The following is a description of a gene set: studied in species Homo sapiens In this study, we provide a molecular signature of highly enriched CD34+ cells from bone marrow of untreated patients with chronic myelogenous leukemia (CML) in chronic phase in comparison with normal CD34+ cells using microarrays covering genes. Expression data reflected several BCR-ABL-induced effects in primary CML progenitors, such as transcriptional activation of the classical mitogen-activated protein kinase pathway and the phosphoinositide-3 kinase/AKT pathway as well as downregulation of the proapoptotic gene IRF8. Moreover, novel transcriptional changes in comparison with normal CD34+ cells were identified. These include upregulation of genes involved in the transforming growth factorbeta pathway, fetal hemoglobin genes, leptin receptor, sorcin, tissue inhibitor of metalloproteinase 1, the neuroepithelial cell transforming gene 1 and downregulation of selenoprotein P. Additionally, genes associated with early hematopoietic stem cells (HSC) and leukemogenesis such as HoxA9 and MEIS1 were transcriptionally activated. Differential expression of differentiation-associated genes suggested an altered composition of the CD34+ cell population in CML. This was confirmed by subset analyses of chronic phase CML CD34+ cells showing an increase of the proportion of megakaryocyte-erythroid progenitors, whereas the proportion of HSC and granulocyte-macrophage progenitors was decreased in CML. In conclusion, our results give novel insights into the biology of CML and could provide the basis for identification of new therapeutic targets. Human Gene Set: DIAZ_CHRONIC_MYELOGENOUS_LEUKEMIA_UP Genes up-regulated in CD34+ cells isolated from bone marrow of CML (chronic myelogenous leukemia) patients, compared to those from normal donors. from publication Diaz-Blanco E, Bruns I, Neumann F, Fischer JC, Graef T, Rosskopf M, Brors B, Pechtel S, Bork S, Koch A, Baer A, Rohr UP, Kobbe G, von Haeseler A, Gattermann N, Haas R, Kronenwett R (PMID 17252012), and this is the list of marker genes: EIF1B, PTBP3, KCNK5, PKIG, UPF3B, RRN3, SELENOW, GTF2B, ACOT9, GUCY1B1 (guanylate cyclase 1 soluble subunit beta 1), HMGCR, ABL1, USP9X, PTPN12, DGCR2, NLK (nemo like kinase), H2AZ2, PDHX, MLLT10, RSL24D1, WDR1 (WD repeat domain 1), GEMIN4, SPTLC1, MBNL2, EIF2AK1, YTHDC1, ETFA, MYL4, TFDP1, GART, XRCC5, ZNF410, ITGA4, VPS33B, PPP2R1A, RPS27L, MAP4K4, DNMT3B, CNOT8, KLF1, TRAPPC3, SLC37A4, MCM3, DDB1, TIMM17A, EPOR, PPIH, AASDHPPT, IL1B, ENOPH1, ARRB1, CYP51A1, BTK, HSD17B12, MGAT4B, NBAS, MLH1, SNX3, ATXN10, NDUFB6, TCEA1, DPAGT1, MORF4L2, MEN1, KHDRBS1, CASP6, EIF1AX, CSNK2A1, FNTA, SLCO4A1, IL1RAP, PSMB2, SUB1, SLC2A1, CDK2, PSMD7, PSMA1, RHOH, PLXNC1, GTPBP4, VTI1B, PMP22, DHCR24, FLOT2, ARF3, EIF4E, SHMT1, TRIM13, ZEB2, TCEAL9, GNB2, TGFB1, ELOC, LMNA, SLC1A5, TTC33 (NCBI Gene Id 23548), FDPS, UQCRC1, PFN1, PNN, GDI2, ACTR1A (actin related protein 1A), SEC31A, NPAT, TFRC, RAP2B, PICALM, ALAS1, NDFIP1, PCK2, SOS2, GTF3C3, KCTD3, TIA1, MAP4K5, PMS1, TDG, HDAC1, CORO1C, GDE1, PIP5K1B, RBM7, EIF3A, ISCA1, GCDH, SLA, GTF2I, PSMD8, SNRPN, ZFAND6, AGPS, PRKAR2B, TFR2, FDFT1, BNIP2, YTHDF2, UBE2G1, S100A10, LCP2, FSCN1, SSBP1, GSS, UROD, UBE4A, SF3A3, MRPL3 (NCBI Gene Id 11222), PTBP1, VPS72, PTPN13, SH3BGRL, ENTR1, ACAT1, ARFGAP2, PFKP, ELP1, SNRPB2, RANGAP1, CALM1, AKAP1, CLC, UPF1, SLC25A15, SRSF9, EBAG9, MTCH2, TNFAIP1 (NCBI Gene Id 7126), TAF6, ATP7A, SLC2A10, PAPSS1, EIF5, FKBP5, SRP72, TAF7, PSMD10, TCF12, ZNF146, CAST, PSMA3, RAD50, OAZ2, PRMT5, POLR2B, ARPP19, GDF11, ACY1, SLC16A1, LBR, PARP1, ATP1A1, BLVRB, CCT8, POLD2, RRAGA, CBX1, CLNS1A, RPL31, USP14, WDR44, SNX4, RPN2, SIAH2, PACSIN2, CASP8AP2, SDF4, RP2, TBXAS1, UBXN8, LAT, PUM2, PRKAG1, GLT8D1, DAZAP1, TXNL1, CNPY2, NOLC1, KLHL12, MAP3K5, DRG1, HBD, SLC29A1, TBPL1, ACBD3 (acyl-CoA binding domain containing 3), CETN2, ECD, STAM, DLEU1, PABPN1, ITPRID2, MXI1, SPTBN2, SRSF1, PDCD6, DSTN, LYPLA1, COPS5, POLR2E, CALU, PPP4R1, DDX1, MED13, MAGOH, NGRN, DEAF1, CNBP, RNF5, MARCHF6, SQSTM1 (sequestosome 1), CUL4A, ATP5PO, TMX1, ENPP2, PPP3CA, FKBP4, SPTA1, SAMSN1, AGPAT1, PPP2CA, NPRL3, TOMM22, ELF4, PPM1D, PTPN7, P2RX5, SNRPG, TAF2 (TATA-box binding protein associated factor 2), ZMPSTE24, RAC1, BRCA1, PPP2R5E, RPA1, TMBIM1, NDUFAB1, DNM1L, KEAP1, SOD2, YEATS4, MPST, CBX3, CLEC2B, AMMECR1, CYC1, SMAD4, ATP5MC3, ARID4B, PSMD1, STAU1, HEBP2, HBS1L (HBS1 like translational GTPase), RBM5, CAPN7, QPCT, UCHL5, XPC, GLUD1, PFDN4, KARS1, HMGB1 (high mobility group box 1), TUBGCP4, HSPA13, NUDT4, RAB38, PPIE (peptidylprolyl isomerase E), HIBCH, POLR2C, MIPEP, PRPSAP2, MATR3, SEPTIN2, CHERP, KLHDC2, ACYP1, SERPINE2, HNRNPC, RBBP8 (NCBI Gene Id 5932), YY1, ACP1, ZNF22, FAS, MSH2, ARL1, MBD4, GCLC, SAV1, SMARCC1, DECR1, LPCAT3, MAPRE2, ATP6V1B2, ALDH6A1, CLPTM1, IMMT, SULT1A2, SNU13, HNRNPH2 (NCBI Gene Id 3188), TSC22D1, DEGS1, SPAG7, SF3A1, TMEM59, ATP6V1A, ACTR3, SLC5A3, TTF2, DGUOK, YES1, HSPH1, ACTL6A, BRD7, ZNF277, CAD, PEX2, FASN, CCDC6, ZFP36L1, MINPP1, LRRFIP2, PLAA, TOPBP1, SMC2, DCTD, PHYH, HBG1, XK, KDM3B, HEBP1, NDUFV2, HBB, MIF, INPP1, GMDS, NPEPPS, MAD2L1, EIF3C, LEPROT, INTS6, CDC7, PSMA7, SRPK2, CETN3, CCNH, APEH, ATP5F1B (ATP synthase F1 subunit beta), PRKD3, DYNC1LI1, BTBD1, DHX9, CITED2, TGM2, PDGFC, TM2D1 (TM2 domain containing 1), RAB31, MSN, GMCL1, IQGAP2, P4HA1, RTCB, NCK1, FXN, PITPNA, PRPF19, RTN4 (NCBI Gene Id 57142), RASSF1, SEC24B, USP11, CLPX, LUC7L3, EIF3B (eukaryotic translation initiation factor 3 subunit B), GMNN, TCP1, DDX11 (DEAD/H-box helicase 11), LSM8 (LSM8 homolog, U6 small nuclear RNA associated), SCAF11, NIF3L1, RBM3, AGL (amylo-alpha-1, 6-glucosidase, 4-alpha-glucanotransferase), TAF6L, CAPNS1, DLD, ITGA2B, POLR1C, MAP2K1, EIF3I, GBE1 (NCBI Gene Id 2632), WBP11, CDC16, COX15, CSDE1, POLE2, U2AF2, PGD, RNF6, PTPRA, HMBS, ADCY7, ABCE1, NET1, CENPS, IVD, NMT1 (N-myristoyltransferase 1), TIMM23, MAN2A1, PSMD12, MAEA, ATRX, PSMG1, TAGLN2, ADGRG1, PTGS1, TERF1, BIRC2, POLRMT, ITPR2 (NCBI Gene Id 3709), VDAC3, SOCS2, TRIP12, OXSR1, PRKACB, GMPR, METAP2, RBM39, WSB2, FRG1, BRD1, XPO1, SSR1, FEM1B, ACOT2, NFYB, DCTN4, FAM117A, COPS2, SMC4, F11R, G3BP2, DNAJC7 (NCBI Gene Id 7266), SRP19, UBE2K, POLE3, ELOVL5 (NCBI Gene Id 60481), RNF130, GATA1, DDX21, KIF22, CDC123, CYTH2, EIF4ENIF1, BAZ1A, LAMTOR3, HK2, CHD1L, LYN, EID1, MFNG, MPV17, ATP5MF (ATP synthase membrane subunit f), PRKAB1, DDX23, DNAJC12, CD59, ASMTL, ZNF134, FOXK2, SNW1, PPP2R5A, PRMT1, SRRM1, AKAP17A, COPA, ETFDH, NUP107, MAP7 (NCBI Gene Id 9053), AHR, PSIP1, HMGB3, HDC, PRDX4, ACVR1, ZNF207, LDHB (NCBI Gene Id 3945), TOMM20, SLC25A11, EIF2D, CAPRIN1, MLST8, GARS1, RSU1, CMPK1, NFATC3, RPS6KA3, ACTR2, SIGMAR1, AKT1, B3GALNT1, SMARCC2, ASL, SF3B3, CDC23, RFC4 (replication factor C subunit 4), CERS2, COIL (NCBI Gene Id 96825), CCT3, BCAP29, GTF2H4, STK11, UBE4B, HBQ1, CRBN, GOSR2, CD36, TOP1, NOMO1, KHSRP, RIPOR2, PPP2R5C, LY6E, ADH5, ITM2A, CISH, ERCC8, UBE2D3, RALB, GHITM, HOXA9, NUP50 (nucleoporin 50), PSMC3, PSMA2, NELFA, SRP54, OGDH (oxoglutarate dehydrogenase), HDAC3, RTN3, MAP2K2, FH, MRM2, STK24, RANBP2, CDK8, ATG12, SRSF10, C1QBP, NUDT6, CGGBP1, DNAJB6, WRN, RAP1GDS1, DCTN6, TSG101, TRA2A, HDGFL3, HIRA, DAG1 (dystroglycan 1), ADAM8, KPNB1, TUBGCP3, ATP5IF1, COPB2, BECN1, AMPD3, CD47, ADSS2, ORC5, ABCC1, PSMC1, RFC3, ENOSF1, MPP1, PNMA1, API5, NQO2, NCOA1, PSMB5, ANXA7, PTOV1, GLE1 (NCBI Gene Id 8012), RSC1A1 (NCBI Gene Id 6248), SREBF2, EHD1, PLP2, HDAC6, AUP1, PPM1A, TNPO3, PPP1R12A, SHMT2, DKC1, KIF2A, SLC9A6, CANX, ACSL1, NMI, IDE, COMT, INPP4B, GM2A, ICMT (isoprenylcysteine carboxyl methyltransferase), UBE2E1, HPGDS, TNFAIP8, MAP1LC3B, PWP2, RAC2, TST, ARF1, FAM8A1, TP53I3, PTPRC, HTATSF1, MRPS30, NNT (nicotinamide nucleotide transhydrogenase), PCBD1, DPP3, PRDX6, TPM1, SRSF3 (serine and arginine rich splicing factor 3), ZKSCAN7, IKZF1, PRR13, NMT2, EIF4B, GET3, PEBP1, YWHAZ, SART3, PCMT1, UBAP2, TMED3, ZPR1, NFE2L2 (NFE2 like bZIP transcription factor 2), NARF, HNRNPA0, HOXA10, KYNU, RYBP, DNAJA3, ZNF24, HAT1, PSTPIP2, CTPS2, NIT2, TIE1, CDK2AP1, TM9SF1, EIF3J, DPM1, AP3B1, CRADD, PDF, SUPT20H, ECI2, HMGCS1, CLIC4, SLC39A8, PMPCB, MRPS31, MICU2, PLIN2, SMARCA5, KDSR, ETNK1, ALDH1A1, TSPAN4, NDUFA8, ANAPC10, PSMD2, PSMC6, AIFM1, PTPN22, GALC, NFKB1, NBR1, GAR1, CUL5, ARPC3, MAPK1 (mitogen-activated protein kinase 1), CMAS (NCBI Gene Id 55907), UBA2, MORF4L1, AZIN1, PMS2P3, NUP98, PDCD10, SEC11A, ELAVL1, TSNAX, NDEL1, UGGT1, DEK, UBE2N, ARFIP1, MRPL49, LANCL1, PCCA, STAU2, PPOX, CPOX, AIMP1, GNS, GATA2, RBM26, SMC3, USP22, GNL3, SEPHS2, CPD, CBFB, ABCC4, HSPA9, IFITM2, ITPA, AP2M1, MDH2, PPP1CC, TXN, DFFB, PEF1, CLIC2, SRSF2, RUVBL1, ARF4, TPI1, TBL1X, CCT2, CAMLG, TIMP1, SRSF4, DUSP12, CASP8, KDM5B, ZNF267, PIK3C3, CACYBP, NME1, POLR1D (RNA polymerase I and III subunit D), THAP12, GATD3, WDR3, MKRN1 (makorin ring finger protein 1), KIFAP3, CCNG1, TXNRD1, COPS3, FARS2, PPT2, NT5C, MRPS35, UBE2D2, CSF2RB, TRIM16, MYCBP, GLO1, CASP10, TFCP2, MED6, RCL1, VPS4B, ORC2, ALDH4A1, MRPL58, ARL5A, WDR11, TP53BP2, CPSF1, FKBP1B, LSM5, COPS4, SLC30A9, GALNT2, PGAP6, LARP1, TEK, SEPTIN7 (septin 7), GNL2, NCBP1, ERG28, BCKDHB, GNAI3, ZMYND8, DYRK1A, MSH6, PGRMC2, RALBP1, HSPG2, PRDX3, ATP6V0E1, PPID, ANP32A (acidic nuclear phosphoprotein 32 family member A), SCARB2, R3HDM4, ACAD8, BNIP3L, AKAP8L, GET1, YARS1, SF3B4, GCSH, UROS, BEX3, PTX3, MTIF2, RHAG, MED17, SUMO1, ACSL4, NEMF, MTMR2 (NCBI Gene Id 8898), PLSCR1, STOML2, TXNDC9, SDCBP, PUS1, GSR, SMARCA2 (SWI/SNF related, matrix associated, actin dependent regulator of chromatin, subfamily a, member 2), XPNPEP1, TMOD3, BSG, VARS1, PCCB, ACSL5 (NCBI Gene Id 51703), USP1, AK2, LMAN1, CPVL, SEPHS1, HP1BP3, UBE2E3, EMP3, NPTN, ABCB6, GGH, KPNA3, HPRT1, CD7, KCNH2, CD63, SRI, CNOT7, GSPT1, QTRT1, STAT5A, PARVB, PRPS1, GOT2, ARCN1, CFLAR, ADK, RAB6A, DCUN1D1, EIF2S2, ILK, CSNK1D, PIM1 (NCBI Gene Id 82453), C1D, RTCA, DARS1, MED12, BNIP3, CDYL, ACLY, PRKRA, PRKDC, TBCE, SLC12A6 (NCBI Gene Id 9990), CSNK1G3, ODC1, ILF3, DDX10, VPS41, CD55, UBAC1, VAMP7, MPDU1, ACO2, PSMA4, KATNA1, SCD, PKP4, TADA3, BMI1, PIGN, C11orf58, TIMM10B, TOPORS, LEPR, SOD1, FLNA (NCBI Gene Id 8272), SCP2, NFE2, CUL4B, HNRNPAB, TBCB, CKB, GTF2A2, ENSA, CAPN15, ALG5, CSF1, MTHFD1, IL7, RAB11A, VPS26C, ATIC, LSM1, STAT3, ANXA1, PGRMC1 (NCBI Gene Id 10857), SEC63, CD84, RNFT1, ISYNA1, MTX2, NCBP2, SLC18A2, BTBD2, ITGB1BP1, STAP1, ACAA2, TRAK2, KCMF1, CDC5L, DR1, NUDT3, MRE11 (MRE11 homolog, double strand break repair nuclease), ATF2, TWSG1, CRIP1, ATP7B, CAPZA2, HDAC7, SMNDC1, CTNND1, HS2ST1, TBK1, RANBP1, IDH3B, DAD1, SNCA, REST, NMD3, CREG1, ERGIC3, MATK, CRY1, NDUFC2, ZNF217, UBE2G2, NSMAF, CSNK1A1, RAB9A, DUSP11, CD2AP, SUOX, ZNF302, GNAQ, HBP1, NUP54, SPINT2, UBQLN2, KTN1, CYCS, PDAP1, TM9SF2, RAD17, PILRB, PSMG2, HMG20B, KEL, GMFB, SS18 (NCBI Gene Id 6760), TM9SF3, RANBP9, KPNA4, PPP1R7, FKBP3, PSMF1, NUDC, IFITM1, STAR, ALAD (NCBI Gene Id 210), URI1, TMEM165, DBF4, FADS1, CAB39, CTCF, SIRT1, UTP3, PPA2, MGST2, FHL2, DNM2, TBRG4, CHP1, NUP153, BUD23, FEZ2, MTA1, GCLM, SGPP1, PTGES3, NDUFS4, LMO2, TLK1, NAP1L4, PCYT2, ABCD3, STAG2, ARIH2, CDC42BPA, PDLIM5, LAPTM4B, RNF14 (ring finger protein 14), IPO5, UGP2, RBBP4, DNAJA2, EIF4H, PSMB1, ATP6V1E1, AHCYL1, MTHFD2, PBX3, XPOT, POLR2K, S100A6, PISD, MYC, SLC38A2, PPM1B, RPA2, FOXN3, FBXW2, CCNI, RAP1A, TSC2, NCOR1, RASA1, BAG4, TMED2, PSMD3, PDCD4, CAPZB, LMO4, PYROXD1, RYK (receptor like tyrosine kinase), NDUFA5, ANXA4, HK1, PTP4A2 (NCBI Gene Id 8073), PDHA1, KRAS, TFDP2, HLTF, ARPC1A, STAT5B, SARS1, SREBF1, GEMIN2, BMAL2, GAS2, SRPK1, WT1, MMS19, UBE2B, AIMP2, IFRD1, ACSM3, IMPA1, LSM4, AMD1, PWP1 (PWP1 homolog, endonuclein), CFH, HNRNPK (heterogeneous nuclear ribonucleoprotein K), CTNNA1, PHKB, LIN7C, NIPSNAP2, PRKCQ, SRSF5, SRD5A1, GRB10, DHRS9, CHPT1, RALA, VCL, HADHB, PHC1, MEIS1, RER1, PAICS, SMAD2, EIF4E2, G3BP1, ARAF, PRKAR1A, ZNF281, MICU1, PPP2CB, CTNNBL1, ING2, IPO7, KMT5AP1, LSS, FANCF, ECHS1, HTRA2, PDCD6IP, VPS26A, DUT, PIK3CB, ST13, RPS6KC1, VBP1, MARCKSL1, ALKBH1, SCFD1, STRAP, ARHGEF3, ARL2BP, HNRNPA3P1, TXN2, ETF1, PDHB, VRK2, OXCT1, UBP1, FOXO3, YKT6, TFG, ALDH5A1, MARCKS, ZMYND11, ATP2A2, AKR1C3, KLRG1, UBE2M (NCBI Gene Id 9040), RAD1, MAN2A2, MSMO1, FLII, SNRPD1, B3GNT2, MAT2B, SNAP23, HMG20A, TMEM50A, ERBIN, NIPSNAP1, ILF2, YME1L1, ALDH18A1, CNIH1, ITGAE, ICAM4, WDR13, NAPA, CDH1, PEX1, POGLUT1, ACO1, GFI1B, MIS18A, DAPK1, FBXO7, HSD17B4, SNX1 (NCBI Gene Id 6642), PEX6, SEMA4D, RCC1, NME7 (NCBI Gene Id 29922), SH3GLB2, WIPF1, SKP1, PITPNB, GMPR2, QDPR, ANAPC1, RAD23B, RBM14, PDCD2, PCTP, CPNE3, DDX41, SNX5, ALG3, EPS15, ATP6AP2, EPB41, PPP1R8, PUM1, SUPT16H, TARS1, ANAPC5, RAPGEF2, STAT4, ZFR, MMUT, MATN2, MDH1, SEC23IP, PAIP1, CFDP1, RBMS1, NPM3 (nucleophosmin/nucleoplasmin 3), PPAT, SMS, PLOD2, PHB2, ALDH9A1, SELPLG, NBN, PTPN6, MLLT3 (MLLT3 super elongation complex subunit), GTF2F1, ADPRM, NUDT21, F2RL1, PCNP, ETS2, CRKL, GALNT1, CD46, CPSF6, MEST, PLA2G12A, LDB1, MED21, SPOP, STK25, NDUFB5, SQLE, TAL1, PPP6C, PGK1, PNP, ACADM (acyl-CoA dehydrogenase medium chain), SINHCAF, SERINC3 (serine incorporator 3), SKIC8, BCL2L1, HACD1 (NCBI Gene Id 9200), DRG2 (NCBI Gene Id 1819), CD82, UBE2V2, SLC43A1, ARL6IP5, TERF2IP, BRD8, FZD7, AQP3, SNRPD3, TCERG1, TARDBP, ABCF2, CDC27, ASH2L, OAT, DLC1, RGS10, SULT1A1, EIF2B1, EIF3M, GOLPH3, RREB1, MARK3, DRAP1, CCT6A, CASP3, SELENOF, ADORA2B, NFATC1, RO60, ABI1, CHIC2, BLMH, RHOG, ASAP2, PIGC (phosphatidylinositol glycan anchor biosynthesis class C), SLC25A32, VAV3, MTR, SDHD, PPP2R1B, HSP90AB1, FADS2, MED4, BUB3, TAX1BP1, HNRNPR, CDC42EP3, CTH, F2R, CYTL1, PFKM, MLF2, HMGN4, MAGEF1, PHF20, RAD21, MDM1, PLTP, RNASEH1, ANGPT2, BCAT1, MRPS15, ATP5PF, COPS8, SLC7A5 (NCBI Gene Id 8140), UTP25, BID, UBTF, ORC4, HADHA, DHX15, HDAC2, SLBP, USP21, RAB4A, PNO1, GRSF1, RBPJ, SSB, C4A, UPF3A, ZSCAN9, HNRNPF, GTF2H1, FECH, RRAS2, CHST2, EXOC5, SLC27A2, ATP2C1, CEP70 (NCBI Gene Id 80321), NAMPT, MFAP1, TAF9, CDC37 (cell division cycle 37, HSP90 cochaperone, NCBI Gene Id 11140), PCM1, EIF4G1, RAP2C (RAP2C, member of RAS oncogene family), ACOT7, FCGR2A, LXN, MCCC2, RBBP7, VAPA, EIF4G2, CLDND1, STXBP3, RIDA, NCF4, KCNN4, SUCLA2, SORD, APBA2, ATXN1, CDK7, SUCLG1